Given this list of marker genes CDK1, PTPN11, JAK2, MAPK3 (mitogen-activated protein kinase 3), JAK1, TYK2, IL6, IL6ST, MAP2K1, IL6R, here is a description of the gene set: Mitogen-activated protein kinase kinase MAP2K1 (also known as MEK1) is a dual threonine and tyrosine recognition kinase that phosphorylates and activates MAPK3 (ERK1). studied in species Homo sapiens part of: RAF-independent MAPK1/3 activation Reactome Pathway: MAPK3 (ERK1) activation